Given this list of marker genes ADORA1, CDA, POLR2B (RNA polymerase II subunit B), POLR1B, OARD1, ACTN4, PNP, POLR3B, here is a description of the gene set: species: Homo sapiens Binding to a nucleoside, a compound consisting of a purine or pyrimidine nitrogenous base linked either to ribose or deoxyribose. Human Gene Set: GOMF_NUCLEOSIDE_BINDING